Given this list of marker genes Plscr5, Clptm1l, Mfsd2a, Serinc5, Ano9, Abca1, Xkr4, Atp8b2, Serinc3, Ano6, Atp8b1, Plscr3, Plscr1, Atp11a, Ano5, Ano2, Atp8b5, Ano10, Abca12, Serinc2, Atp8a1, Abca4, Atp10b, Abcb1b, Atp8b4, Xkr9, Ano7, Atp9b, Atg9b, Ano1, Xkr8, Tmem30b, Abcb1a, Tmem41b, Atp10d, Abca7, Atp11c, Atp10a, Abcb4 (ATP-binding cassette, sub-family B member 4), Plscr1l1, Abcg1, Ano8, Ano4 (anoctamin 4), Atp11b, Vmp1, Atp8b3, Abca3, Plscr4, Plscr2, Ano3, Tmem30a, Vdac2, Abca2, Atp8a2, Atp9a (NCBI Gene Id 11981), Atg9a, here is a description of the gene set: Enables the transport of a lipid from a region of a membrane to a different region on the same membrane. studied in species Mus musculus Mouse Gene Set: GOMF_INTRAMEMBRANE_LIPID_TRANSPORTER_ACTIVITY